Given this list of marker genes MED19, TSHZ1, DCAF1, DNAJC11, ELP2, HARBI1, TLCD1, B4GALT6, ATRN, MAP2K5, EPC2, DSG2, CRK, DHDH, PXK, MDM2 (MDM2 proto-oncogene), SPRING1, CD109, DPP4, GZF1, STRADA, MYC, OR10AD1, CLCN7, C8orf33, HRAS, CC2D2A, TMX3, APOE, IL6, PPP2R5E, ZNF292, EIF2B3, ATF5, GYPC, SDC4, TMEM167B, DCN, UBXN2A, PTPN23, PRSS50, PAOX, AP4B1, VPS35L, RIPOR1, PFKFB3, RLF, SLCO4A1, DOP1B, ADCY2, RBM28, DNAJC27, ZNF236, FKBP7, METTL5, GRB14, SMARCC2, LOXL2, GCLM, CYP7B1, RNF19B, SYK (spleen associated tyrosine kinase), METTL15, TRMT61A, LZTFL1, STX6, PRKRIP1, TMCC1, APPBP2, RASGEF1B, CWC27, UBFD1, CAD, TMEM176B, GNL3, PRSS46P, FAM43A, ACOT8, PANX1, IFT56, TGFB3, RAB20, CRNKL1, UBAP2, ZBTB45, ILVBL, GABPB1, PLA2G4A, HDDC3, HEATR1, STAG3, PLCXD3, PRELID3B, UBXN7, EGFR, DIO2, CXCL1, SMPD4 (sphingomyelin phosphodiesterase 4), CCNB3, PRR14 (NCBI Gene Id 78994), SCAMP1, OXLD1, MORN2, PHTF1, RNF5, METTL25B, SLC48A1, DAB2IP, LRRTM4, MUC5B, NCK2, APLP1, TCAF2 (NCBI Gene Id 285966), HEXA, NPM3, EGR1, DMAC2 (NCBI Gene Id 55101), ZFYVE26, ZFAND5, PHF20L1, CENPJ, GPR153, TAF4B, KLHL12, TIMM9, PLXNA1, MECOM, NCDN, CSRNP1, FTSJ3, H2BC13, ASB7, C2CD4B, ZNF131, SLPI, CXCL6, TMEM9, RPAP1, RAD51D, EIF5, MAOA, PPP1R1A, TES, DUS3L, ISY1, KDM6B, EFEMP2, SAMD4B, POLR1C, PTPRG, IGF2R, JUN, C2CD2, VPS26B (VPS26 retromer complex component B), PRKAB2, UFD1, ZNF469, DUSP4, MTUS1, ITGB7, FAM98B, MKRN2, GADD45A, ISCA2, PHGR1, TRPC4AP, WDR46, GEM, KLHDC1, INSIG2, MRC1, PSMG2, EREG, NACC2, ETFRF1, RNF44, QTRT2 (queuine tRNA-ribosyltransferase accessory subunit 2), PTCH1, TGFBI, TRIM13, PPP1R10, NECTIN3, CD40, SCN4B, RNF167, CCDC54, TNF, SLC31A1, COL8A1, PRXL2A, PLAC8, ANXA9, ZNF513, GPBP1, ZMYM2, PIM3, ABCB6, SLC29A3, GPR101, PCNT, here is a description of the gene set: IRAK-4 is an essential component of the signal transduction complex downstream of the IL-1- and Toll-like receptors. Though regarded as the first kinase in the signaling cascade, the role of IRAK-4 kinase activity versus its scaffold function is still controversial. In order to investigate the role of IRAK-4 kinase function in vivo, ‘knock-in’ mice were generated by replacing the wild type IRAK-4 gene with a mutant gene encoding kinase deficient IRAK-4 protein (IRAK-4 KD). Analysis of bone marrow macrophages obtained from WT and IRAK-4 KD mice with a number of experimental techniques demonstrated that the IRAK-4 KD cells greatly lack responsiveness to stimulation with the Toll-like receptor 4 (TLR4) agonist LPS. One of the techniques used, microarray analysis, identified IRAK-4 kinase-dependent LPS response genes and revealed that the induction of LPS-responsive mRNAs was largely ablated in IRAK-4 KD cells. In summary, our results suggest that IRAK-4 kinase activity plays a critical role in TLR4-mediated induction of inflammatory responses. Genes up-regulated in comparison of untreated wild type macrophages at 1 h versus those from IRAK4 deficient mice treated with LPS (TLR4 agonist) at 1 h. from publication Koziczak-Holbro M, Glück A, Tschopp C, Mathison JC, Gram H (PMID 18266302) Human Gene Set: GSE9037_WT_VS_IRAK4_KO_LPS_1H_STIM_BMDM_UP species: Homo sapiens